Given this list of marker genes IL15RA, MDK, IL6R, ZEB1, NAB2, MAPRE2, EVI2A, IGF2, OSM, FGF7, FOSL1, EMP1, BCAT1, REG1B, GRPR, GAS6, FGA, TNFSF9, RUNX3, EMP3, EGR4, CHRM3, IL1A, IGF1, TIMP1, PDGFB, ZFP36L2, SLAMF1, BST2, PSPHP1, TACSTD2, TGFB3, BTG1, IL18, SPOCK1, FGF4, CXCL10, PDGFRA, EDNRA, KLF6, INSIG1, AREG, IL15, BCAR1, MST1R, OSMR, CD2, CD5, LAMP3, CD4, IL1B, VIP, TGFA, ERBB2, CD8A, TSPAN3, GRN, HBEGF, CD81, EPS8, CD8B, GCG, MXD1, ISG20, CSRP2, CREG1, CSF3, AKR1C3, IL6, CSF1, EGF, MYC, ENPEP, CXCL1, CDK5R1, CRIP1, EPHB4, PRDX1, PDGFA, NRP1, DAB2, PPBP, IL2RG, FGB, CCN1, LRP1, LIF, CCL14, SFN, NAMPT, FGG, PTN, VEGFC, ERG, VIPR1, CD86, BCL6, EDN1, IL3, here is a description of the gene set: Genes in the cancer module 121. Human Gene Set: MODULE_121 studied in species Homo sapiens